Given this list of marker genes IFNA17, IFNA8, UBC, EP300, ELOC, UBB, IRF3, IFNB1, IFNA2, N, RPS27A, IFNA4, IFIH1, STAT2, JAK1, RBX1, 1B, IFNA10, EIF2AK2, UBA52, IFNA14, 1C, ELOB (elongin B), TRIM25, IFNA1, IFNAR2, IFNA5, CUL5, IFNA7, MAVS, IFNAR1, IFNA6, CREBBP, TYK2, RIGI, IFNA16, IFNA21, here is a description of the gene set: Reactome Pathway: Evasion by RSV of host interferon responses Infection with human respiratory syncytial virus (hRSV) is typically associated with low to undetectable levels of type I interferons (IFNs). Several hRSV proteins interact with host innate immune system factors that support the type I interferon response. Nonstructural proteins NS1 and NS2 localize to mitochondria and nucleus where they bind MAVS, DDX58, TRIM25, IRF3, and CREBBP, affecting DDX58/IFIH1-mediated interferon induction. Additionally, hRSV nucleoprotein interacts with MDA5 downregulating the interferon response and with PKR (EIF2AK2) blocking the innate immune system signal for shutting down protein translation. Further interactions of the M, SH, and G proteins are reviewed by van Royen et al, 2022. studied in species Homo sapiens part of: RSV-host interactions